Given this list of marker genes CLDN5, TJP1, CBFB, OCLN, RUNX1, here is a description of the gene set: The RUNX1 transcription factor, which functions as part of the RUNX1:CBFB complex, was shown to directly transcriptionally regulate expression of several genes that encode components of tight junctions. Namely, RUNX1 binds to promoters of TJP1 (encoding ZO-1), OCLDN (encoding Occludin) and CLDN5 (encoding Claudin-5) and stimulates their transcription. Downregulation of RUNX1 by microRNA miR-18a negatively regulates expression of these three tight junction genes, which may affect the permeability of blood-tumor barrier in glioma. Reactome Pathway: RUNX1 regulates expression of components of tight junctions species: Homo sapiens part of: Transcriptional regulation by RUNX1